Given this list of marker genes LY9, SLAMF7, MEI1, PELI1, HSP90B1, JCHAIN, XBP1, SSR4, SEC11C, RAB30, ITM2C, DERL3, MZB1, BLOC1S5-TXNDC5, POU2AF1, CD27, FKBP11, H1-10, FCRL5 (Fc receptor like 5), CREB3L2, TENT5C, IGHA1, HERPUD1, CD79A, here is a description of the gene set: from publication Aizarani N, Saviano A, Sagar, Mailly L, Durand S, Herman JS, Pessaux P, Baumert TF, Grün D (PMID 31292543) Human Gene Set: AIZARANI_LIVER_C38_RESIDENT_B_CELLS_3 species: Homo sapiens